Given this list of marker genes Foxo4, here is a description of the gene set: Reactome Pathway: FOXO-mediated transcription of oxidative stress, metabolic and neuronal genes electronically inferred by orthology from the curated human pathway part of: FOXO-mediated transcription This event has been computationally inferred from an event that has been demonstrated in another species.<p>The inference is based on the homology mapping from PANTHER. Briefly, reactions for which all involved PhysicalEntities (in input, output and catalyst) have a mapped orthologue/paralogue (for complexes at least 75% of components must have a mapping) are inferred to the other species. species: Mus musculus